Given this list of marker genes Sec61g, Zfand2b, Arxes1, Ppp1r15a, Get4, Grik5, Naca, Zfand2a, Ubac2, Ddrgk1, Sec62, Srp68, Folr1, Tram1l1, Ssr3, Gja1, Gbf1 (NCBI Gene Id 73518), Kdelr2, Rab3gap2, Srp72, Get1, Hspa5, Fkrp, Ankrd13c, Sppl2c, Sec61a2, Sgta, Srp54c, Chmp4b, Bag6, Spcs1, Frey1, Kdelr3 (KDEL (Lys-Asp-Glu-Leu) endoplasmic reticulum protein retention receptor 3), Srp54b, Sec61b, Sec63, Sec61a1, Akt1, Btf3, Get3, Ywhae, Herpud1, Sgtb, Vapa, Os9, Vps54, Sec16b, Folr2, Man1a, Ryr2, Arxes2, Bcap29, Srprb, Srp14, Mia3, Lrrk2, Tram1, Rer1, Mia2, Ubl4a, Srp19, Sting1, Tram2, Rab10, Glp1r, Bcap31, Rab3gap1, Kdelr1, Macf1 (NCBI Gene Id 97195), Srp9, Spcs3, Gabarapl2, Srpra, Ank2, Edem1, Sec16a, Insig1, Spcs2, Insig2, Rtn4, Srp54a, here is a description of the gene set: Mouse Gene Set: GOBP_PROTEIN_LOCALIZATION_TO_ENDOPLASMIC_RETICULUM species: Mus musculus A process in which a protein is transported to, or maintained in, a location within the endoplasmic reticulum.